The following is a description of a gene set: Human Gene Set: GSE3039_NKT_CELL_VS_B2_BCELL_UP Genes up-regulated in NKT cells versus B2 B lymphocytes. species: Homo sapiens Three innate (B1-B, NKT, CD8aaT cells) and adaptive (B2-B, CD4T, CD8abT cells) cell-types were sorted by FACS. Three biological replicates for NKT, CD4T, CD8aaT, CD8abT cells and two biological replicates for B1 and B2 cells were generated and the expression profiles were determined using Affymetrix Mu74Av2 chip. Comparisons between the sample groups allow the identification of genes differentially expressed between the innate and adaptive cell-types. from publication Yamagata T, Benoist C, Mathis D (PMID 16623764), and this is the list of marker genes: DOCK5, STAB2, ERI1, CD5L, CIITA, KDM2B, TMEM26 (NCBI Gene Id 219623), LANCL2, NEURL1B, LANCL1, DDR1, C1QB, AKAP11, SLC16A9, CALHM2, SETX, PTPRC, KIF13A, CD209, CCDC93, KCNK6, ESPL1, EVL, TRIM44, DHDH, NHSL2, PTGIR, INPP5F, CD79A, CEACAM21, LPCAT1, MARCO, API5, MDP1, PLXND1, TDRD3, TUFM, NUCKS1, GALNT3, ZNF445, EPS15, JCHAIN, FAM117A, IGLC7, UBA2, CYLD, NADK, DAGLB, MAN1A1, NUP210, SEMA6D, DAPK1, OBI1, PRTN3, B4GALT4, OPA1, TATDN3, PLD4, S1PR5, ACER3, RNASEH2B, ADAT2, TBXAS1, GPX1, ABCC4, HPS3, HFE, SLC4A1, USP5, PDLIM1, LIFR, HPGD, TSSC4, FLVCR1, CD1D, LDLRAD3, POLR3B, GM2A, TMC6, RRAS2, SULF2, MRAS, KLHL20, ACSS1, HEMGN (hemogen), EMP3, RIPK1, PIP4K2A, RNF141, NAIF1, EPB41L3, CTBP1, ALDH1A2, ELANE, AHCYL2, GSTO1 (glutathione S-transferase omega 1), GP2, LIMD2, ANPEP, MPO, ITGA4, C2, CCDC88A, TUSC1, SPIC, VWA8, AHSP, ARHGAP18, AGAP1, PRG4, AK3, HYCC1, HIPK2, PIGH, ZC3H12D, CHD1L, MLEC, HEBP2, PPCS (NCBI Gene Id 79717), F5, SLC5A3, ADD3, BATF3, CYRIA, CFH, TMEM176B, CD2, HNRNPUL2, ANP32E, C1QA, ABI2, RCAN1, SERPINB6, SLC9A9, CHD6, SPN, QPRT, AP1M1, CNTLN, SASH3, NCKAP1L, CAT, ATP8A1, CXorf38, TMEM107, TACC1, TMEM64, STK4, CTSF, HACD4, APH1B, RDH10, HR, NONO, DERA, FCGRT, ABCB7, DPP4, CBL (Cbl proto-oncogene), ARL5A, CTSG, RASGRP2, C1orf54, MYCL, ZER1, PIKFYVE, TFDP2, SLC45A3, SGPP1, PTPRM (protein tyrosine phosphatase receptor type M), SLC40A1, PARN, FLT3, TNFRSF21, PDPR, RAMP1, C1QC, SSRP1 (NCBI Gene Id 6749), GPR18, RIMS3, POSTN, BCAS3 (BCAS3 microtubule associated cell migration factor), POU2AF1, IDS, CD7, NSMAF, CEP68, SLC4A7, RNF168, PLBD1, ARHGEF10, KLK8, CD79B, TIA1, VKORC1, ST6GALNAC2, KRT80, INTS10, ACO1, SMAGP